Given this list of marker genes Mapk1, Crkl, Ptpn11, Ywhab, Fbxw7, Yes1, Lck, Crk, Leo1, Scaf4, Samsn1, Grap, Ldlrap1, Shc1, Cblc, Pik3r2, Mapk3 (NCBI Gene Id 26417), Pik3r3 (phosphoinositide-3-kinase regulatory subunit 3), Sh3bp2, Pin1rt1, Shd, Rasa1, Syk, Grb10, Btrc, Shb, Acp2, Sh2d3c, Ptpn3, Cblb, Nck2, Pcif1, Sh2d1b1, Pin1, Hck, Ywhaz, Pik3r1, Bcar3, Ywhae, Fgr, Stap1, Pfn1, Sla, Abl1, Sirpa, Irs1, Vav2, Shc3, Arrb1, Scaf8, She, Zap70, Sfn, Ptpn6, Socs3, Vav1 (NCBI Gene Id 22324), Plcg2, Cbl, Abl2, Grap2, Nedd4, Ptpn5, Rtf1, Grb2, here is a description of the gene set: Binding to a phosphorylated amino acid residue within a protein. Mouse Gene Set: GOMF_PROTEIN_PHOSPHORYLATED_AMINO_ACID_BINDING studied in species Mus musculus